The following is a description of a gene set: species: Homo sapiens Any process that activates or increases the frequency, rate, or extent of interferon-alpha production. Human Gene Set: GOBP_POSITIVE_REGULATION_OF_INTERFERON_ALPHA_PRODUCTION, and this is the list of marker genes: DDX3X, TBK1, TLR3, TLR4, MMP12, IRF5 (interferon regulatory factor 5), IFIH1, RIPK2, DHX36, IRF7, DHX9, CHUK, SETD2, STAT1, TLR9, NMBR, TRIM65, MAVS, ZC3HAV1, RIGI, HSPD1, HMGB1, IRF3, TLR8, TLR7 (toll like receptor 7), NMB